Given this list of marker genes HRAS, LYN, SOS1, RAPGEF1, EPO, NRAS, KRAS, IRS2, JAK2, CRKL, SHC1, EPOR, VAV1, GRB2, here is a description of the gene set: Reactome Pathway: Erythropoietin activates RAS The RAS guanine nucleotide exchange factors SOS1 and VAV1 bind indirectly to the phosphorylated EPOR via CRKL, SHC1, and GRB2. The phosphorylated cytoplasmic domain of EPOR binds CRKL, which is then phosphorylated. Phosphorylated CRKL binds SHC1, which is then phosphorylated and binds either GRB2:SOS1 or GRB2:VAV1. SOS1 and phosphorylated VAV1 catalyze the exchange of GDP for GTP bound to RAS, that is, RAS:GDP is converted to RAS:GTP. part of: Signaling by Erythropoietin studied in species Homo sapiens